Given this list of marker genes LMNA, COL5A2, NPR3 (natriuretic peptide receptor 3), TGFBR3, IPO8, TGFB2, FBN2, ANGPTL6, MYPN, SPECC1L, GANAB, DNAJB11, ERCC6, LOX, COL1A2, TPM3, ZFX, ENG, PGM3, COL1A1, ELN, MID1, B3GAT3, SLC2A10, KANSL1, ABL1, ALG5, TGFBR2, THSD1, ATP2B1, HEY2 (NCBI Gene Id 30830), COL5A1, MAT2A, EFEMP2, TPM2, SMAD2, MYLK, MYH11, HNRNPK, ERCC8, ACTA2, CHST3, B3GALT6, TGFB3, RAP1B, ALG9, FBN1, ALDH1A2, BGN, PRKG1, PKD2, COL3A1, MFAP5, SMAD4, PKD1, THSD4, IFT140, DNMT3A, SMAD3, CARS1, TGFBR1, KCNH1, AFF4, FMR1, ROBO4, PPP1CB (protein phosphatase 1 catalytic subunit beta), BICC1, FOXE3, NKAP, PIGN, AEBP1, here is a description of the gene set: species: Homo sapiens Aortic root aneurysm An abnormal localized widening (dilatation) of the aortic root. Human Gene Set: HP_AORTIC_ROOT_ANEURYSM